Given this list of marker genes RAB1B, SMARCA2, DENND2B, CLDN18, HOXA2, PIM1, CARMIL3, WASF2, RPSA, NTRK3, FLRT1, NOL4, ORC4 (origin recognition complex subunit 4), MXI1, PXK, C1QC, GNG3, LRIT3, HOXB3, HMGCS1, STRN3, STC1, USP3, PITPNC1, HOXA9, CRAMP1, HOXC4, MDM2, ZBTB9, ARHGEF6, FAM219A, DGKA, ANGPT2, RTL3, ZBTB21, GRIN2A, RAP2B, CACNB2, LZTS2, CITED4, LTBP1 (NCBI Gene Id 4052), GNAI2, HSD11B1, HOXA11, FGF9, WDR82, BATF2, ABCD1, ABCA12, TSC22D1, TMBIM1, ERBIN, CREBZF, MICALL2, CTRL, LRP1, TECTA, NDP, CACNG2, HMG20B, LRRTM3, LMTK2, SMOX, SLC6A9, PRRX1, ABCC5, EIF4E, NLGN2, RCE1, DMD, RUSC1-AS1, CFAP65, NFE2L1, LIPT2-AS1, SREK1, PPM1D, SRRM4, RBM5, DOCK9, BCL11B, ERRFI1, CHMP2B, LRRK1 (leucine rich repeat kinase 1), NXPH4, CDC73, DNAJC7, ZNF362, SLC7A9, ELK3, PIDD1, FGF11, LRRC2, WHRN, PKP3, TTN, RNF144B, SPTBN4, CITED1, NKIRAS2, MTA2, PTAFR, TSHR, TJP2 (NCBI Gene Id 9414), RAB44, INHBB (NCBI Gene Id 3625), IFFO1, EI24, HAUS3, STARD8, IL10, GNAQ, IL24, ING1, CNOT4, PML, FGD4, SENP2, WWP1, DLX5, TNFSF4, LUC7L3, RAB43 (RAB43, member RAS oncogene family), ILVBL, MON1A, OTX1, HCAR2, USP12, RIN1, IL7R, PTCHD4, SLC36A2, RCOR1, CLN5, BSCL2, PA2G4, DYRK3, RARB, NKX2-3, RARA, UBL3, LINC02875, ETV1, PPL, AP1G2, TBX5, ZMAT3, MAP3K13 (mitogen-activated protein kinase kinase kinase 13), SALL4, TLX1, PLEKHA8P1, MLLT6, ING3, SPATC1, PHKG1, NCAM2, EDC4, OPA3, VAX1, GRIPAP1, PHF8, PXN, DAB2IP, ETFB, TBC1D8, EYA2, ADD3, TAF5, PRDM12, SHISA6, NRG1, DHX30, BIRC8, POM121L1P, ANXA1, FGF20, PTH1R, HNRNPA0 (heterogeneous nuclear ribonucleoprotein A0), GJB4, SLCO3A1, SLC16A13, PTPRG, RFTN2, ASCL4, ZEB2, SLC4A4, TGFB3, PLA2G4E, BAZ2A, PSME2, SLC7A1, KDM4C, DNAI1, TLE4 (NCBI Gene Id 7091), BTK, LDB3, TBX21, TSPAN1, DNAH6, TRERF1, IL20, ENTR1, KRT15, ARHGEF37, SLITRK1, LRTM1, WBP1L, ARK2N, MSL2, EGFR, AKAP6, AP4S1, FHDC1, HOXD10, SEMA6D, MYH1, RPS19, EFHD1, TRIM29, CELF6, RORC, NSD3, DLG2, ANKRD13B, TDRD3, PLEKHA6, HIP1R, APOLD1, SLC1A3, MSTN, CDKN1A, EP300, MPZL2, MYH11, GRK6, PIP4P2, HEBP1, PREX2, RHOBTB2, STARD7, COPB1, ADAMTS4, ZNF654, BLVRB, NUP54, KCTD5, MAF, S100PBP, DST, CHD5, CIZ1, DLX3, CACNA1A, ENSG00000291228, BMF, DNAJB5, NTRK1, BMPR2, UPK3A, here is a description of the gene set: Genes having at least one occurrence of the motif RGRCAWGNCY in the regions spanning 4 kb centered on their transcription starting sites. This matches the TP53 transcription factor binding site V$P53_DECAMER_Q2 (v7.4 TRANSFAC). Human Gene Set: P53_DECAMER_Q2 studied in species Homo sapiens